Given this list of marker genes GPM6A, PCDH15, ATP1B2, CEND1, KIF13A, IDH1, CHKB-CPT1B, APOL6 (apolipoprotein L6), DNM3, GRID2, AGA, BRINP2, ZMAT3, KCNQ2, LINGO1, THY1, SCRG1, ARC, SEL1L3, CACNA1G, TIMP4, KIF14, LGR5, AK4, TAF1B, MYT1, FGFBP3, SOX2-OT, DNAH7, ATP13A2, GAB1, CACNG2, SLC9A7 (NCBI Gene Id 84679), BIRC3, KRT17, LHFPL2, CGREF1, ZCCHC24, CPNE2 (copine 2), PLEKHH2, WFDC1, IGFBP2, BAMBI, FABP5, CNMD, FICD, B4GALT6, EGFR, SCUBE2, ADAM22, PMP22, SLITRK2, CHST11, SLITRK1, AFF1, SCG3, FALEC, SOX5, ATP13A4, DHX32, NCAM2, BIRC5, ITM2C, ARHGAP11A, VXN, GRM5, NTM, NEK6, DCLK2, PHYHIPL, B4GALNT1, SPRED1, CSMD3, HES5, LRRC4C, PHACTR3, GRID1, ARHGAP23, PCDHA7, BIVM-ERCC5 (NCBI Gene Id 100533467), PTN, RUNDC3A, LPAR4, MMP16, BCHE, ITGB5, METRN, ATP1B1, UHRF1, DND1, KCNE5, CRTAC1, SIRT2, LRRTM4, FAM182B, APOD, ELFN2, BOC, PHGDH, CTHRC1, TMOD2, AIF1L, GNAL, SOX2, CCND2, NLGN1, PLPPR1, ARL8A, SAPCD2, LRRTM3, ASTN1, SOX9-AS1, CCDC39, OLIG2, HEPACAM, KCND2, NLGN4Y, TAFA5 (TAFA chemokine like family member 5), GNG4, FAM89A, WNT7B, ZGRF1, SLC35F1, PRKCQ-AS1, CTNND2, FABP7, PHLDA1, ERF, SERPINE2, SLC7A11, NEIL1, PCDHGC3, SLITRK4, DNAAF3, TTK, ACSS1, ADAMTS3 (NCBI Gene Id 9508), HBG2, ITPKB, KCNJ1, BCLAF3, TAOK3, HBA1, CHTF8 (NCBI Gene Id 54921), CMYA5, FYN, OSBPL6, GATM, GRIA4, NLGN3, FAM181B, TSPAN12 (tetraspanin 12), LIMA1, MAML2, COL2A1, QKI, ASCL1, RAB9A, NKX2-2, TRAF4, RIMS1, ATCAY, ERBB3, FXYD6, INTS1, GABBR2, SPRY4, PLLP, BAALC, MIR9-1HG, GRIA3, BRINP1, IFI27L2, INHBB, SEZ6, CDK7 (NCBI Gene Id 116024), SPATA6, DOCK1, ANKRD44, PTPRE, HEPN1, UBL3, MT3, OLIG1, LHFPL3, C2orf72, PDGFRA, C21orf58, LINC03124, SLC1A2, MMP2, PREX1, PID1, ROBO3, MDGA2, SCD5, CASK, KRT14, RNF144A, NHERF1, SOX9, HSH2D, GPM6B, NCAPH, CSGALNACT1, LRP1, CNTN1, SLC25A16, TTYH1, CADM2, RTKN2, EVI2A, NDRG2, SCAMP2, SDC3, CEP83-DT, OMG, ATP2B4, ZFP36L1, CACNG7, BUB1B, KCNIP1, SLC22A17, NFIX, MCTP1, PCDH11X, WSCD1, ADCYAP1R1, ADGRG1, PPP2R2B, OPHN1, PBK, PLPPR2, ETV5, ETV1, EFCAB14 (NCBI Gene Id 9813), CSPG5, CHN1, CALCRL, SKA3, ELF1, TF, EPN2, AKAP7, ITGB8, BLOC1S1, NPAS3, PRKCA, JPH3, PIF1, SERINC5, HAGH, TRIM67, IGF1, TNK2, PDE1C, TMEM35B, ANGPTL2, PTPRZ1, PEA15, GAL3ST1, CCDC175, EDNRB, TNS1, THUMPD2, CRYL1, NKAIN4, RARG, SSPOP, MAP3K1, SGO1, LUZP2, DNER, SCN1A, SLC9A9, NELL1, AFAP1L2, CACFD1, BARD1, TMT1A, TSPAN7, NRXN1, ANKS1B, PXDC1, ITGAV, ARHGAP42, ADGRB1 (NCBI Gene Id 575), GPR17 (NCBI Gene Id 91962, G protein-coupled receptor 17), SLC16A14 (solute carrier family 16 member 14), TAFA2, TOP3A, C1QL1, KANK1, C1orf21, CA1, SRI (sorcin), PSD, GAREM2, BRINP3, SCN3A, SORCS3, MT2A, RIT2, PTPRT, TRIM68, CDCA7L, STK32B, SALL3, SOX8, NTRK3, NXPH1, NALF1, KLRC2 (NCBI Gene Id 3822), SOX6, HBA2 (NCBI Gene Id 3040), GFOD1, HBB, NETO1, TYMS, ADAMTS6, TPPP, OPCML, SLC6A1, DBI, COL9A1, SCARB1, SEZ6L, DPP6, CREB5, RFTN2, SOX1, HBG1, PLAT, COL9A3, LMOD3, XYLT1, SHC3, TAMALIN, SNTG1, SGO2, SH3D19, LRRK2, GNG7, PRDM8, RAB31, NLGN2, PLPP4, EGR1, CADM4 (cell adhesion molecule 4), SMOC1, IGSF9B, DSEL, ITPR2, GRB14, PCDHGB4, GRAMD1C, CPEB1, PMP2, TMOD1, PCDH17 (protocadherin 17), EID2B, EYA2, GTSE1, SLC44A1 (NCBI Gene Id 63942), BCAN, SLC15A2, here is a description of the gene set: species: Homo sapiens Human Gene Set: MANNO_MIDBRAIN_NEUROTYPES_HOPC from publication La Manno G, Gyllborg D, Codeluppi S, Nishimura K, Salto C, Zeisel A, Borm LE, Stott SRW, Toledo EM, Villaescusa JC, Lönnerberg P, Ryge J, Barker RA, Arenas E, Linnarsson S (PMID 27716510) Cell types are named using anatomical and functional mnemonics prefixed by 'm' or'h' to indicate mouse and human respectively: OMTN, oculomotor and trochlear nucleus; Sert, serotonergic; NbM, medial neuroblast; NbDA, neuroblast dopaminergic; DA0-2, dopaminergic neurons; RN, red nucleus; Gaba1-2, GABAergic neurons; mNbL1-2, lateral neuroblasts; NbML1-5, mediolateral neuroblasts; NProg, neuronal progenitor; Prog, progenitor medial floorplate (FPM), lateral floorplate (FPL), midline (M), basal plate (BP); Rgl1-3, radial glia-like cells; Mgl, microglia; Endo, endothelial cells; Peric, pericytes; Epend, ependymal; OPC, oligodendrocyte precursor cells.